Given this list of marker genes OPA1, SEM1, PSMC2, PSMC6, PAK2, PSMA5, PSMC4, PSMB3, PSMD6, PSMB1, RPS27A, PSMD8, PSMC3, PSMB2, UBB (NCBI Gene Id 91253), PSMB4, PSMA4, PSMA2, PSMD3, PSMD7, PSMB5, PSMD1, PSMA6, ADRM1, PSMD2, PSMD13, PSMA3 (proteasome 20S subunit alpha 3), PSMD14, ARHGAP10, PSMD11, PSMC5, UBC (NCBI Gene Id 7316), PSMC1 (NCBI Gene Id 5700), PSMB7, OMA1, UBA52, PSMA7, PSMA1, PSMB6, PSMD12, here is a description of the gene set: part of: Apoptosis studied in species Homo sapiens Reactome Pathway: Regulation of Apoptosis A regulated balance between cell survival and apoptosis is essential for normal development and homeostasis of multicellular organisms (see Matsuzawa, 2001). Defects in control of this balance may contribute to autoimmune disease, neurodegeneration and cancer. Protein ubiquitination and degradation is one of the major mechanisms that regulate apoptotic cell death.